Given this list of marker genes TNPO1, DDX52, CST7, IL10RA, TUFM, KIAA0232, PHF2, FXN, VWA8, SLC4A7, PRCP, ATP5PF, HLA-DPA1, HOMER2, ACOT8, ENSA, AIMP2, CD1D, CDR2, CSK, ZRSR2, CD1A, PICALM (NCBI Gene Id 8301), BLVRA, SMAD7 (NCBI Gene Id 4092), CDK2AP1, CD151 (NCBI Gene Id 977), HNRNPU, ZZEF1, KCNQ1, MISP (mitotic spindle positioning), ANP32A, VDR, ADSS2, TPM1, NDST1, SATB1, XYLT1 (NCBI Gene Id 64131), TIMP3, RNF126, TCF12, DEGS1, HNRNPA2B1 (NCBI Gene Id 3181), IL27RA, MAPK8IP1, PALLD, GABPB1, ZNF117, FLI1, RPS6KA5, PAK2, SEC14L1 (NCBI Gene Id 6397), ATP2B1, YWHAH, MAOA, CSNK1G2, PMP22, NF2, ID3, NUP58, WSB2, SPR, ST6GAL1, RBPJ, BEX4, TLX1, ABCC4, HLA-DQB1, TNR, CTSC, SLC25A36, TUBA1A, MARCHF7, PLEC, RCHY1, GPX7, ICMT, IL1RN, GGCT, SLC7A8, GNMT, PPP2CA, DPM2, ADO, SPRY2, CH25H, LAMP3, ISCA1, RANBP9, MPHOSPH8 (NCBI Gene Id 54737), LMO2, XPOT, GTF2A1, DPY19L1, TACSTD2, ANXA7, SPTAN1, ECHS1, BRD8, H2AZ2, GNPAT, WNT5A, STX12, KIF5C, IRAG2, WSCD1, MAP1B, AP1B1, MINK1, SYNGR4, DDX5, MDM4, PLCB2, GRIN2C, QPRT, LAPTM4B, MYCBP, PCK1, EPB41, RNF44, MSMB, DHH, ALDH1A2, KLC1, GSPT1, ATP5MG, ACAA2 (NCBI Gene Id 147548), PPM1B, FURIN, CLC, PLAU, PRKDC, TUBB7P, CELA2A, PTP4A1 (NCBI Gene Id 7803), NUDC, NCOR2, ACADS, ASMTL, SYCP2, GDE1 (NCBI Gene Id 53591), PCSK5, MMP12, RAB3GAP1, MCM5, PPM1F, TWF1, TPM4 (tropomyosin 4), LY75, HLF, PPFIBP2, CYB5R3, AHCYL2, POLR3C, FES, MBNL1, ACRV1, AUH, ANPEP, TGDS, MAP3K14, QPCT, DOK2, PCDHB11, ABCG1 (ATP binding cassette subfamily G member 1), PNPLA6, CLIC2, PSKH1, IL1R1, BAAT, MICAL2, GSTP1, DAAM1, ADORA3, PFKFB1, TXNIP, ABCC3, TFAP4, BCAR3, CLEC10A, SEL1L3, CYCS, PIK3CG, MYH9, INTS10, INPP5E, ATXN1 (NCBI Gene Id 7912), DDX3X, C1QBP, GSTT1, RAB5C, ATIC, PDHB, AKAP8L, MTCL1, CCR1, PDHA1, TBC1D1, ST14, MAPKAPK3, here is a description of the gene set: Monocyte-derived dendritic cells (DC) and macrophages (MΦ) generated in vitro from the same individual blood donors were exposed to five different pathogens, and gene expression profiles were assessed by microarray analysis. Responses to Mycobacterium tuberculosis and to phylogenetically distinct protozoan (Leishmania major, L. donovani, Toxoplasma gondii) and helminth (Brugia malayi) parasites were examined, each of which produces chronic infections in humans yet vary considerably in the nature of the immune responses they trigger. Genes up-regulated in comparison of dendritic cells (DC) exposed to 50 worm/well B. malayi versus macrophages exposed to 50 worms/well B. malayi. from publication Chaussabel D, Semnani RT, McDowell MA, Sacks D, Sher A, Nutman TB (PMID 12663451) studied in species Homo sapiens Human Gene Set: GSE360_DC_VS_MAC_B_MALAYI_HIGH_DOSE_UP